The following is a description of a gene set: Mouse Gene Set: GOBP_SEMI_LUNAR_VALVE_DEVELOPMENT studied in species Mus musculus The process whose specific outcome is the progression of a semi-lunar valve over time, from its formation to the mature structure., and this is the list of marker genes: Gata4, Tgfb2, Slit3, Rb1, Gata5, Heyl, Rhoa, Jag1, Emilin1, Smad6, Adamts5, Efna1, Smad2, Pcdha9, Tbx20, Gata3, Hey2, Axin2, Adamts19, Tnfrsf1a, Tnfrsf1b, Bmpr2, Robo1, Tgfb1, Stra6, Hey1, Eln, Bmp2, Bmp4, Sox9, Dll4, Twist1, Nfatc1, Tgfbr2, Robo2, Slit2, Notch2, Tie1, Nos3, Gja5, Notch1, Rbpj (recombination signal binding protein for immunoglobulin kappa J region)